Given this list of marker genes PSMD9, PSMD8, PSME3, PSMD7, PSMD3, PSMD10, PSMC4, PSMD5, PSMC2, SEM1, PSMD1, PSME2, PSMC6, PSMD13, PSMD14 (proteasome 26S subunit, non-ATPase 14), PSMD12, PSME1, PSMC1, PSMD11, PSMD6, PSMD4, ADRM1, PSMC5, PSMD2, PSMC3 (proteasome 26S subunit, ATPase 3), here is a description of the gene set: Human Gene Set: GOCC_PROTEASOME_ACCESSORY_COMPLEX studied in species Homo sapiens A protein complex, that caps one or both ends of the proteasome core complex and regulates entry into, or exit from, the proteasome core complex.